The following is a description of a gene set: Reactome Pathway: BMAL1:CLOCK,NPAS2 activates circadian expression As inferred from mouse, BMAL1:CLOCK (ARNTL:CLOCK) and BMAL1:NPAS2 (ARNTL:NPAS2) heterodimers bind to sequence elements (E boxes) in the promoters of target genes and enhance transcription. part of: Circadian clock species: Homo sapiens, and this is the list of marker genes: NCOA1, NPAS2, CARM1, KLF15, HELZ2, NOCT, TBL1XR1, BHLHE41, RXRA, CLOCK, AVP, SERPINE1, BHLHE40, CREBBP, BMAL2, NAMPT, F7, CHD9, NCOA2, PPARA, BMAL1, NCOA6, TBL1X, MED1 (NCBI Gene Id 9327), SMARCD3, TGS1